The following is a description of a gene set: Bifid tongue Human Gene Set: HP_BIFID_TONGUE Tongue with a median apical indentation or fork. studied in species Homo sapiens, and this is the list of marker genes: ALX3 (NCBI Gene Id 93575), NEK1, CEP120, C2CD3, FZD2, OFD1, IFT80, DYNC2H1, HNRNPK, GRIP1, FREM2, MCTP2, DYNC2I1, DHCR7 (7-dehydrocholesterol reductase), WDR35, RIPK4, WNT5A, DVL3, ROR2, DDX59, DYNC2I2, NXN, FRAS1, DVL1, IPO8